Given this list of marker genes Serpine1, Serpine2, Snx12, Furin, Mdm2, Cdh1, Ctla2a, Ctsz, Il1r2, Sirt4, Fmr1, Serpinf2, Lrrk2, Chac1, Cpb2, Ppp1r15a, Gas1, Usp17le, Plat, Thbs1, Acp4, Plau, Tmem98, Glg1, here is a description of the gene set: Mouse Gene Set: GOBP_NEGATIVE_REGULATION_OF_PROTEIN_MATURATION studied in species Mus musculus Any process that stops, prevents or reduces the frequency, rate or extent of protein maturation.